The following is a description of a gene set: Any process that modulates the frequency, rate or extent of the activity of the Wnt signal transduction pathway. Human Gene Set: GOBP_REGULATION_OF_WNT_SIGNALING_PATHWAY species: Homo sapiens, and this is the list of marker genes: GPC5, FZD9, RSPO2, KPNA1, TMEM88B, ABL1, MCC (NCBI Gene Id 4163), FGF2, GPC3, CCNYL2, RUVBL1, WNK1, DACT3 (dishevelled binding antagonist of beta catenin 3), AMFR (NCBI Gene Id 267), CSNK1G2, FOLR1, RECK (NCBI Gene Id 8434), SALL1, HDAC1, FZD1, AMER3, MIR212, ZEB2, DAB2IP, DDIT3, ZNF703, FAM53B, CXXC4, ADNP, RACK1, CBY1, TLE5, YAP1, CTNNBIP1, PPM1A, DIXDC1, SOX4, CCNY, PTK7, AXIN1, CSNK1A1, GLI3, VGLL4, SKI, SFRP2, TSKU, FGF9, FOXO1, ADGRA2, MIR1260B, AMER2, PTPRO, RNF43, IFT80, TIAM1, PCDH11Y (protocadherin 11 Y-linked), GRB10, LIMD1, SNX3, SMAD3 (SMAD family member 3), OTULIN, GSK3A, TLE6, LYPD6, EGF, SMURF2, ZBED3, NLE1, CTNND2, TCF7L1, SEMA5A, CMAHP (cytidine monophospho-N-acetylneuraminic acid hydroxylase, pseudogene), MDFI, POU5F1 (POU class 5 homeobox 1), TLE1, LEF1, SMARCA4, CCNYL3, DKK2, CDH2, IGFBP1, DISC1, HNF1B, INVS, MIR501, MKS1, RSPO3, WNT11, USP47, CSNK2A1, MESP1, HMGA2, MIR498, APCDD1, TLR2, MDK, PBXIP1, WIF1, SULF2, DKKL1, PRDM15, AMER1 (APC membrane recruitment protein 1), NKX2-5, CAPRIN2, CSNK1E, NXN, SPIN4 (NCBI Gene Id 139886), CRBN, JADE1, CSNK1G1, GSK3B, SHISA6, G3BP1, APCDD1L, BIRC8, RPS12, HECW1, RUVBL2, RNF14, STK11, FGF10, CDC73 (cell division cycle 73), CCNYL1, SIX3, SMAD4, CITED1, CAV1 (caveolin 1), JRK, VANGL2, SCEL, PPP1CA, PPP2CA, SDHAF2, MESD, SHISA2, MDFIC, SHISA3, NPHP4, APOE (NCBI Gene Id 99), DAAM2, LMBR1L, TNKS2, PLEKHA4, ALPK2, UBR5, BARX1, SULF1, ILK, ITGA3, BMP2, CCAR2, USP34, MACF1, OTUD5, LRRK1, FGFR2, CER1, EMD, WNT5A, CCN4, DAB2, SIAH2, DLX5, SOX17, SHH, EDA, APC, C12orf43, TLE2 (TLE family member 2, transcriptional corepressor), FRZB, TLE7, PPM1N, BAMBI, TMEM132A, SRC, TPBG, TSC2, BICC1, ANKRD6, SOSTDC1, CHD8, NKD1, JUP, IGFBP4, ATP6V0C, LRP1, MAD2L2 (NCBI Gene Id 10459), MAPK14, LZTS2, TMEM237, MDFIC2, RBPJ, MIR346, MLLT3, IFT20, SFRP4, VCP, NPPA, CCDC134, LATS2, UBE2B, FRAT1, NHERF1, TCF7L2, UBAC2, TBX18, DKK1, WWTR1, TNKS, KANK1, MIR203A, BMAL1, SOST, TRABD2B, FUZ (fuzzy planar cell polarity protein), GSC, CYLD, DACT1, NFATC4, ISL1, PPM1B, TLE4, WNK2, PLPP3, SFRP1, EGR1, CDK14, STK4, GNAQ, SOX13, TBL1X, WNT5B, CTDNEP1, TMEM9, WLS, RNF220, CSNK1A1L, SNAI2, HSP90B1 (NCBI Gene Id 7184), MIR19B1, NOG, SPEF1, SCYL2, CCDC88C, ATP6V1C2, VPS35, TMEM131L, TMEM88, SENP2, USP8, CSNK1D, SOX9, RNF213, ZNRF3, FOXL1, BTRC, STK3, PIN1, NLK, DCDC2 (doublecortin domain containing 2), DRAXIN, MIR145, SOX10, ASPM, NPHP3, NKD2, DDX3X, DKK4, TRABD2A, NRARP, CDH3, LGR5, LRP4, CSNK1G3, PPP2R3A, GPRC5B, TNFAIP3, HIC1, CTHRC1, LATS1, FOXO3, TPBGL (NCBI Gene Id 441617), SOX30, WNT10B, FERMT1 (NCBI Gene Id 55612), MIR183, WNT3A, LBX2, KLF15, MIR26A1, LRRK2, GSKIP, TGFB1, GLI1, NOTCH1, TMEM196, MIR29B1, MBD2, TERT, LGR4, DEPDC1B, PRICKLE1, FRMD8P1, ZRANB1, COL1A1, RSPO1, NOTUM, TMEM198, FZD7, FZD6, WNT3, RBMS3, TLE3, IGFBP6, XIAP, SBNO1, NFKB1, TMEM64, EGFR, RBX1, MIR1-1, PSEN1, PTPRU, MIR199A1, APP, TRPM4, KREMEN1, SOX2, DAPK3, ATP6AP2 (NCBI Gene Id 95880), RNF146, PRKN, TAX1BP3, TBL1XR1, WWOX, SFRP5, FRMD8, HMGXB4, DKK3, CTNNB1, LGR6, HHEX, GID8, MIR665 (microRNA 665, NCBI Gene Id 100126315), TMEM170B, CCNYL1B, RSPO4, GREM1, SPIN1, PFDN5, IGFBP2, AXIN2 (NCBI Gene Id 8313), APC2, TTC21B, MIR29C (NCBI Gene Id 407026)